Given this list of marker genes Cdc37l1, Rbm18, Or6d12, Esyt2, Nkiras1, Cep170b, Fgl2, Sema3g, Nova1, Lrrtm2, Rnls, Plscr4 (NCBI Gene Id 235527), Ccdc117, Slc20a1, Zfyve1, Osbpl6, Samt1, Traf6, Wdfy4, Slc10a3, Tdrkh, Btg2, Mri1, Tmem120b, Gm16445, D030056L22Rik, Uqcrq, Eif4g2, Card10, Rassf9, Sbspon, Phc3, Mr1, Slc38a5, Paqr5, Olfm5, Ints2, Cep20, Kras, Bend4, Appl1 (NCBI Gene Id 97938), Abl2, Med1 (NCBI Gene Id 19014), Tgm2, Bcorl1, Snx22, Golph3l, Wdcp, Nfat5 (NCBI Gene Id 54446), Vcan, Flna, Ftdc1, Samt1c, Sntn, Hnrnpa2b1, Samt1d, Zfp532, Gid8, Pls3, Hipk3, Mmp16, Hook3, Slc46a2, Dusp16 (dual specificity phosphatase 16), Eif5a2, Hnrnpd, Ino80d, Erbb4, Stx2, Sec23ip, Hmbox1, Samt1b, Kdm2b, Clasp1, Tanc2, Elf1 (NCBI Gene Id 13709), Prg4, Irak1, Numb, Ptpra, Gatb, P2ry1, Lrrc15, Fbxw2, Lsm11, Cracd, B3gnt5, Dcaf12, here is a description of the gene set: Mouse Gene Set: MIR_146A_5P_MIR_146B_5P species: Mus musculus Genes predicted to be targets of miRBase v22 microRNA mmu_miR_146a_5p, mmu_miR_146b_5p in miRDB v6.0 with MirTarget v4 prediction scores > 80 (high confidence targets). from publication Chen Y, Wang X (PMID 31504780)